The following is a description of a gene set: Reactome Pathway: Sensory Perception species: Mus musculus This event has been computationally inferred from an event that has been demonstrated in another species.<p>The inference is based on the homology mapping from PANTHER. Briefly, reactions for which all involved PhysicalEntities (in input, output and catalyst) have a mapped orthologue/paralogue (for complexes at least 75% of components must have a mapping) are inferred to the other species. electronically inferred by orthology from the curated human pathway, and this is the list of marker genes: Or5d14, Sdc1, Or7g27, Or1e21, Or1e1, Or1a1b, Tas2r144, Pnlip, Or14a260, Gpc2, Or1e31, Nmt1, Camkmt, Or2j3, Sdc3, Or10g9b, Apoa1, Scnn1a, Akr1c18, Or51ai2, Sag, Rdh12, Tas2r105, Gnat3, Or8u9, Or1n2, Or7c70, Or10g9, Or4q3, Or2a20, Tas2r138, Akr1c20, Stra6, Dhrs3, Or2t47, Awat2, Or5al1, Bco1, Or1e26, Or8b56, Or13c3, Or11h4, Lrp10, Opn1sw, Or56a5, Tas2r120, Bco2, Tas2r118, Or4l1, Apoc2, Tas1r3, Or1e30, Cnga1, Tas2r126, Apoc3, Akr1b10, Or10s1, Gnat1, Lrp8, Or2a51, Or51d1, Tas2r139, Or2f1, Or1e33 (olfactory receptor family 1 subfamily E member 33), Rdh10, Pde6g, Akr1c13, Rgs9bp, Or10g7, Tas2r121, Gpihbp1, Calm1, Lpl, Akr1c21, Tas2r137, Sdr9c7, Myo7a, Or6f1, Akr1c6, Ppef1, Or11h4b, Scnn1g, Gnb5, Or8b3, Or8b3b, Lrp12 (low density lipoprotein-related protein 12), Or1e22, Rbp2, Or1e1c, Or3a1, Tas2r119, Tas2r107, Apoa2, Rbp1, Or2b11 (NCBI Gene Id 257962), Or8k3, Or8d23, Tas2r136, Or4c12, Or11a4, Gngt1, Pde6b, Rdh5, Gnb3, Or1e35, Or51e1, Tas1r2, Apoe, Or1e23, Or1e29, Apob, Or4d2b, Cyp4v3, Apoa4, Or2t46, Or6p1, Scnn1b, Or5k1, Rbp4, Cngb1, Rho, Or1e19, Guca1a, Rgs9, Or14j1, Gpc3, Or1e16, Or5p80, Or2t48, Lrp1, Dhrs9, Or1e32, Rcvrn, Or10x1, Or10g3, Fnta, Tas2r130, Or2at4, Akr1c14, Gucy2f, Or9g20, Or11h6, Or1d2, Hsd17b6, Or5k1b, Or1e34, Or2l13, Tas2r108